The following is a description of a gene set: Genes negatively differentially expressed in cell type: pDC (plasmacytoid dendritic cell) upon treatment with cytokine: IFN-α1 in mouse lymph nodes in vivo. from publication Cui A, Huang T, Li S, Ma A, Pérez JL, Sander C, Keskin DB, Wu CJ, Fraenkel E, Hacohen N (PMID 38057668) Mouse Gene Set: CUI_PDC_IFNA1_RESPONSE_DN Cytokines mediate cell-cell communication in the immune system and represent important therapeutic targets. A myriad of studies have highlighted their central role in immune function, yet we lack a global view of the cellular responses of each immune cell type to each cytokine. To address this gap, the authors created the Immune Dictionary, a compendium of single-cell transcriptomic profiles of more than 17 immune cell types in response to each of 86 cytokines (>1,400 cytokine-cell type combinations) in mouse lymph nodes in vivo. A cytokine-centric view of the dictionary revealed that most cytokines induce highly cell-type-specific responses. For example, the inflammatory cytokine interleukin-1β induces distinct gene programmes in almost every cell type. A cell-type-centric view of the dictionary identified more than 66 cytokine-driven cellular polarization states across immune cell types, including previously uncharacterized states such as an interleukin-18-induced polyfunctional natural killer cell state. studied in species Mus musculus, and this is the list of marker genes: Zfhx3, Cep164, Il16, Aff3, Pgls, Fth1, Rack1 (receptor for activated C kinase 1), Clec12a, Bri3bp, Sox4, Ccr2, Eid1, Spns3 (SPNS lysolipid transporter 3, sphingosine-1-phosphate (putative)), C1qbp, Nop53, H2-DMa, Eif3m, Prcp, Mef2c, Cmah, AU020206, Sms, Tcp11l2, Naa30, Tmem147, Fnbp1, Ppfia4, Ikbip, Pycard (NCBI Gene Id 66824), Nrip1, Pik3cg, Ciita, Ccr5, Pdia5, Kctd12, Alox5ap, Smc3, Trappc5, Irag2, Itgb7, Cnot6l, Foxp1, Gusb, Pold4, Arhgdib (NCBI Gene Id 11857), Gpi1, Fau, Upb1, Luc7l2, Mmgt2, Sptssa, Smc6, Smad7, Eif4b, Slc43a2, Smim14, Bnip3l, Phgdh, Samsn1, Smarcc1, Srpk2, Kxd1, H2-DMb1, Ccpg1 (NCBI Gene Id 72278), Ptpn18, Pim2, Nedd4, Cdip1, Fyb1, Eef1a1, Rb1cc1, Anp32b (NCBI Gene Id 67628), Cd79b, Hmgb2, Erp29, Cd209d, Satb1, Baz2b, Man2a2, Eef1g, Siglecg, Camk1d, Cox7a2l, Snx29, Khk, Eif3e (eukaryotic translation initiation factor 3, subunit E), Macroh2a1, Mdp1, Tsc22d3, Gmfg, Mri1, Dap, Colgalt1, Rfx7, H2az2, Dipk1a, Ablim1, Tprg1l, Tex261, Clasp2, Gria3, Nsa2, Hint1, Ctnnd2, Prkacb, Kdm7a, Lamtor2, Hnrnpa1, Rmnd5a, Rnf130, Eif3k, Trf, Cd48, Tspan13, Clec4g, Ramp1, Mxd4, Mrps26, Cat, Asph, Jun, Eef2, Bin1, Ypel3, Naca, Cirbp, Fam98c, Arhgef6, Irf2, Pfdn5 (prefoldin 5), Eif3f, Idh2, Uba52, Ebpl, Top2b, Fxyd5, Eef1d, Cyfip1, Rnaset2b, Atp1b1, Xkrx, Syk, Slamf6, Pdcd4, Paics, Mtss1 (NCBI Gene Id 70087), Eif4a2, Klrd1, Exosc5, Lamtor4, Atraid, Igf1r, Selenoh, Klhl24, Phb1, Marcks, Klf2, Bmyc, Galnt1, Atp5mc2, Tep1, Lat2, Cdk4, Imp3, Fcrla, Eci2, Banf1, Eif3h, Cd209a, Tmem191, Cacna1e, Gm2a, Peli2, Eef1b2, Npm1, Kmo, Zeb2, Slc4a7, Clcn5, Ctsd